The following is a description of a gene set: studied in species Homo sapiens Human Gene Set: GOBP_PROTEIN_STORAGE The accumulation and maintenance in cells of proteins. Protein reserves can be accumulated during early developmental stages for mobilization and utilization at later stages of development., and this is the list of marker genes: TLE6, OOEP, NLRP5, PADI6, KHDC3L